The following is a description of a gene set: Mouse Gene Set: GOBP_REGULATION_OF_GUANYLATE_CYCLASE_ACTIVITY studied in species Mus musculus Any process that modulates the frequency, rate or extent of guanylate cyclase activity., and this is the list of marker genes: Rd3, Adora2b, Guca1b, Nos3, Guca1a